Given this list of marker genes KCNE3, SDHA, MEN1, SDHD, SDHAF2, CDKN2A, APC, EPAS1, VHL, SDHB, KCNQ1, CDKN1C, MDM2, CDKN1B, RET, CACNA1S, KCNQ1OT1, CHEK2 (checkpoint kinase 2), MDH2, TMEM127 (NCBI Gene Id 84178), SDHC, NF1, ZNRF3, DNMT3A, DLST, CYP11B2, IGF2, CTNNB1, SLC25A11, CYP11B1, TP53 (NCBI Gene Id 7157), CDKN1A, CLCN2, IDH2, PRKAR1A, TERT, PTEN, CDKN2B, YY1 (YY1 transcription factor), CDKN2C, CCND1, MAX, SCN4A, IDH1, FH, KIF1B, here is a description of the gene set: A tumor (abnormal growth of tissue) of the adrenal gland. studied in species Homo sapiens Neoplasm of the adrenal gland Human Gene Set: HP_NEOPLASM_OF_THE_ADRENAL_GLAND